The following is a description of a gene set: Human Gene Set: GOBP_NUCLEOLAR_LARGE_RRNA_TRANSCRIPTION_BY_RNA_POLYMERASE_I studied in species Homo sapiens The synthesis of the large ribosomal RNA (rRNA) transcript which encodes several rRNAs, e.g. in mammals 28S, 18S and 5.8S, from a nuclear DNA template transcribed by RNA polymerase I., and this is the list of marker genes: POLR1D, MTOR, POLR2E, TAF1B, POLR1E, MACROH2A2, GTF2H5, MACROH2A1, DDX11, SIRT7, NOP53, SMARCB1, IPPK, NOL11, NCL, DEDD, PWP1, MARS1, TCOF1, PIH1D1, ERCC6, ERCC2, POLR1F, SMARCA4